Given this list of marker genes IFT27, SCAPER, MKS1, BBS10, BBS7, LRP12, ARL6, BBS4 (NCBI Gene Id 585), RILPL1, SCLT1 (sodium channel and clathrin linker 1), CEP19, GRHL3, BBS5, BBIP1, TRIM32, BBS12 (NCBI Gene Id 166379), LZTFL1, UBB, GIPC1, TTC8, SELENOI, CFAP418, IFT172, NPHP1 (nephrocystin 1), BBS1, BBS2, BBS9, CEP290, WDPCP, MKKS, SDCCAG8, NOTCH2NLC, IFT74, here is a description of the gene set: studied in species Homo sapiens Human Gene Set: HP_NASAL_DYSARTHRIA Nasal dysarthria